Given this list of marker genes ODC1, FHL1, IDS, TCIRG1, TCEAL1 (transcription elongation factor A like 1), GFI1, ELANE, LEP, SRP19, CLPB, SPTBN1, KNSTRN, FOXP2, SP110, UBE2A, ALG12, DDOST, MBD5, PIK3CD, here is a description of the gene set: Human Gene Set: HP_RECURRENT_EAR_INFECTIONS Recurrent ear infections Increased susceptibility to ear infections, as manifested by recurrent episodes of ear infections. species: Homo sapiens